Given this list of marker genes TNIP2, FLOT1, HCFC2, CAV1, TRIM3, PELI1, F2RL1, SRC, RNF170 (NCBI Gene Id 96586), RFTN1, TLR3, HAVCR2, COLEC12, WDFY1, UBQLN1, IKBKB, TIRAP, UNC93B1, PTPN22, TRAF6, MAP3K7, SCARA3, TNF, SCIMP, OAS1, FLOT2, TICAM1, TNFAIP3, here is a description of the gene set: Human Gene Set: GOBP_TOLL_LIKE_RECEPTOR_3_SIGNALING_PATHWAY The series of molecular signals initiated by a ligand binding to the endolysosomal toll-like receptor 3. studied in species Homo sapiens